The following is a description of a gene set: The growth phase of the hair cycle. Lasts, for example, about 3 to 6 years for human scalp hair. species: Mus musculus Mouse Gene Set: GOBP_ANAGEN, and this is the list of marker genes: Fermt1, Myo5a, Msx2, Ppard, Dsg4, Krtap21-1, Notch1, Ctnnb1, Wnt5a, Psen2, Psen1 (NCBI Gene Id 19164), Mreg, Ptgs2, Wnt10b, Akt1, Gsdma3